The following is a description of a gene set: from publication Durant L, Watford WT, Ramos HL, Laurence A, Vahedi G, Wei L, Takahashi H, Sun HW, Kanno Y, Powrie F, O'Shea JJ (PMID 20493732) Genes down-regulated in CD4 T cells: STAT3 knockout versus wildtype. studied in species Homo sapiens STAT3, an essential transcription factor with pleiotropic functions, plays critical roles in the pathogenesis of autoimmunity. Despite recent data linking STAT3 with inflammatory bowel disease, exactly how it contributes to chronic intestinal inflammation is not known. Using a T cell transfer model of colitis we found that STAT3 expression in T cells was essential for the induction of both colitis and systemic inflammation. STAT3 was critical in modulating the balance of T helper 17 (Th17) and regulatory T (Treg) cells, as well as in promoting CD4+ T cell proliferation. We used chromatin immunoprecipitation and massive parallel sequencing (ChIP-Seq) to define the genome-wide targets of STAT3 in CD4+ T cells. We found that STAT3 bound to multiple genes involved in Th17 cell differentiation, cell activation, proliferation and survival, regulating both expression and epigenetic modifications. Thus, STAT3 orchestrates multiple critical aspects of T cell function in inflammation and homeostasis. Human Gene Set: GSE21670_STAT3_KO_VS_WT_CD4_TCELL_DN, and this is the list of marker genes: PMF1, PDK1, PPRC1, TRMT1, SFXN4, TFPI2, RAB30, IKZF1, LPAL2, NOLC1, CEACAM1, GNL3 (NCBI Gene Id 26354), TP53, PGM1, PIM1, STK17B, ADD2, MYC, SLC7A1, RASL11A, CCT5, CXCL13 (C-X-C motif chemokine ligand 13), CDCA7L, DIPK1A, SUMO4, POLR1A, MAT2A, HIPK2, PTPN1, SOCS1, SREBF1, TMEM71, ADTRP, NOP14, YARS1, TSEN2, JUNB (NCBI Gene Id 90482), CXCL3, RPF2, EXOSC5, CTPS1, RRP12, SLC7A5, PAICS, IPO5, C1QBP, WDR3, ATP2B4, SLC25A12 (solute carrier family 25 member 12), KPNA6, CERS6, ICOS, NOP58, UTP20, STAMBPL1, MEOX1, NFKBIZ, IMMT, SCFD2, PPP1R3B, PTGER2, KNOP1, TAB2, DDX21, BCL2, ZNF101, IL6, CDK2, XPOT, XRN2 (5'-3' exoribonuclease 2), URB2, VARS1, PLCL1, ALDH18A1, GTPBP4, DARS1, SNTB1, PCED1B, ITK, CSTF2T, CD7, PCGF5, CYTIP, MTHFD1L, JAK3, IL4R (NCBI Gene Id 3566), NOC3L, IL2RA, RRS1, NAA15, MCL1, NARF, SLC11A1, RNF157, CISH (NCBI Gene Id 29917), ZNRF1 (NCBI Gene Id 84937), CXCL1, SLC12A2, CCT3, PITRM1, ETNK1, IL32, POLR1B, ARID5A, ATIC, LCP2, TFDP1, RAB19, WDR12, IARS1 (isoleucyl-tRNA synthetase 1), IKZF4, PRMT3, TNFRSF9, ID2, CCL2, BCL2L1, IL21R, IL5, LDHA, TMEM65, DPP4, SREBF2, PIK3CD, SOCS3, FAM98A, CCL1, EEIG2, SOCS2, BAZ1A (NCBI Gene Id 25985), IL1A, FARSB, DACT1, C3, PHF20L1, HEATR1, SLC9B2, HIF1A, LPCAT3, WDR43, MMD, TIAM1, CCL3, SBNO2, BYSL (bystin like), RAB27B, LINS1, SLC26A11, LARP4, BATF, ARID5B, KDSR, TAF4B, UBALD2, DTNBP1 (NCBI Gene Id 84062), CAD, CXCL6 (C-X-C motif chemokine ligand 6), LRFN2, NSMCE1, HIPK1, ADAM19, SLC39A8, CYSLTR2, NABP1, MIR21, REXO2, IL13 (interleukin 13), QTRT1, SLC37A3, IRF4, PNO1, SFMBT2, NDFIP2, SYNE2, CSF1, CYLD, PLXDC1, CXCL5, CAMK2D, GNPDA1, MAL, MKRN1, CNKSR2, NCOA3, IL1B, C12orf76, KIAA0040, SRM, ITGB8, VAMP4, LRP8, ENO1, PIM2, FURIN, UPP1, BHLHE40, PUS7, CXCL8, RANBP1, BCL6